The following is a description of a gene set: Adipogenesis is the process of cell differentiation by which preadipocytes become adipocytes. During this process the preadipocytes cease to proliferate, begin to accumulate lipid droplets and develop morphologic and biochemical characteristics of mature adipocytes such as hormone responsive lipogenenic and lipolytic programs. The most intensively studied model system for adipogenesis is differentiation of the mouse 3T3-L1 preadipocyte cell line by an induction cocktail of containing mitogens (insulin/IGF1), glucocorticoid (dexamethasone), an inducer of cAMP (IBMX), and fetal serum. More recently additional cellular models have become available to study adipogenesis that involve almost all stages of development. In vivo knockout mice lacking putative adipogenic factors have also been extensively studied. Human pathways are traditionally inferred from those discovered in mouse but are now beginning to be validated in cellular models derived from human adipose progenitors.<br>Adipogenesis is controlled by a cascade of transcription factors. One of the first observable events during adipocyte differentiation is a transient increase in expression of the CEBPB (CCAAT/Enhancer Binding Protein Beta, C/EBPB) and CEBPD (C/EBPD) transcription factors. This occurs prior to the accumulation of lipid droplets. However, it is the subsequent inductions of CEBPA and PPARG that are critical for morphological, biochemical and functional adipocytes.<br>Ectopic expression of CEBPB alone is capable of inducing substantial adipocyte differentiation in fibroblasts while CEBPD has a minimal effect. CEBPB is upregulated in response to intracellular cAMP (possibly via pCREB) and serum mitogens (possibly via Krox20). CEBPD is upregulated in response to glucocorticoids. The exact mechanisms that upregulate the CEBPs are not fully known.<br>CEBPB and CEBPD act directly on the Peroxisome Proliferator-activated Receptor Gamma (PPARG) gene by binding its promoter and activating transcription. CEBPB and CEBPD also directly activate the EBF1 gene (and possibly other EBFs) and KLF5. The EBF1 and KLF5 proteins, in turn bind, and activate the PPARG promoter. Other hormones, such as insulin, affect PPARG expression and other transcription factors, such as ADD1/SREBP1c, bind the PPARG promoter. This is an area of ongoing research.<br>During adipogenesis the PPARG gene is transcribed to yield 2 variants. The adipogenic variant 2 mRNA encodes 30 additional amino acids at the N-terminus compared to the widely expressed variant 1 mRNA.<br>PPARG encodes a type II nuclear hormone receptor (remains in the nucleus in the absence of ligand) that forms a heterodimer with the Retinoid X Receptor Alpha (RXRA). The heterodimer was initially identified as a complex regulating the aP2/FABP4 gene and named ARF6.<br>The PPARG:RXRA heterodimer binds a recognition sequence that consists of two hexanucleotide motifs (DR1 motifs) separated by 1 nucleotide. Binding occurs even in the absence of ligands, such as fatty acids, that activate PPARG. In the absence of activating ligands, the PPARG:RXRA complex recruits repressors of transcription such as SMRT/NCoR2, NCoR1, and HDAC3.<br>Each molecule of PPARG can bind 2 molecules of activating ligands. Although, the identity of the endogenous ligands of PPARG is unknown, exogenous activators include fatty acids and the thiazolidinedione class of antidiabetic drugs. The most potent activators of PPARG in vitro are oxidized derivatives of unsaturated fatty acids.. Upon binding activating ligands PPARG causes a rearrangement of adjacent factors: Corepressors such as SMRT/NCoR2 are lost and coactivators such as TIF2, PRIP, CBP, and p300 are recruited (Tontonoz and Spiegelman). PPARG also binds directly to the TRAP220 subunit of the TRAP/Mediator complex that recruits RNA polymerase II. Thus binding of activating ligand by PPARG causes transcription of PPARG target genes.<br>Targets of PPARG include genes involved in differentiation (PGAR/HFARP, Perilipin, aP2/FABP4, CEBPA), fatty acid transport (LPL, FAT/CD36), carbohydrate metabolism (PEPCK-C, AQP7, GK, GLUT4 (SLC2A4)), and energy homeostasis (LEPTIN and ADIPONECTIN).<br>Within 10 days of differentiation CEBPB and CEBPD are no longer located at the PPARG promoter. Instead CEBPA is present. EBF1 and PPARG bind the CEBPA promoter and activate transcription of CEBPA, one of the key transcription factors in adipogenesis. A current hypothesis posits a self-reinforcing loop that maintains PPARG expression and the differentiated state: PPARG activates CEBPA and CEBPA activates PPARG. Additionally EBF1 (and possibly other EBFs) activates CEBPA, CEBPA activates EBF1, and EBF1 activates PPARG. part of: Adipogenesis Reactome Pathway: Transcriptional regulation of white adipocyte differentiation studied in species Homo sapiens, and this is the list of marker genes: THRAP3, MED8, PCK1, MED22, WNT10B, MED31, MED1, MED23, WNT1, MED13L, MED15, MED11, NCOA2, FABP4, CEBPB, KLF5, NFKB1, HELZ2, EGR2, MED24, TBL1XR1, CDK19, LPL, MED19, NCOA1, NCOR1, MED16, CCND3, MED18, SMARCD3, ADIRF, TGFB1, PPARGC1A, MED26, CREBBP, MED12, ZNF638, MED4, TNF, FAM120B, MED17, MED13 (NCBI Gene Id 9969), MED28, MED29, CDK8, NCOA6, PLIN1, MED6, MED9 (NCBI Gene Id 55090), KLF4, ZNF467, MED25, PPARG, EBF1, RXRA, MED14, SREBF2, CD36, PPARA, CHD9, MED30, MED27, ANGPTL4, CEBPA, MED10 (mediator complex subunit 10), TGS1, CEBPD, HDAC3, NCOR2, MED20, CDK4, NR2F2, TBL1X, LEP, CCNC (cyclin C), RELA, SLC2A4, MED21, CARM1, NCOA3, EP300, ADIPOQ, SREBF1, MED7